Given this list of marker genes ACOT9, TICAM1, CHST2, BHLHE22 (basic helix-loop-helix family member e22), TXNL1, DUSP4, N4BP1, BMAL2, LINC03025, TXLNB, FBRS, CSF2RA, TAGLN2, CLN5, GRAMD1A, IRF7, AMPD3, PPFIBP2, CPA3, SMOX, INHBA, CLDND1, ARF3, GRAMD1C, MTFP1, TARS1, SPHK1, YIPF6, CARD16, TNIP3, SLC44A1, DCUN1D3 (defective in cullin neddylation 1 domain containing 3), MAD2L2 (NCBI Gene Id 10459), EAF1, TMEFF1, OSM, TGFA, ARFRP1, LMNB1, SPRED2, CSF2RB, HCK, MCM5, GCH1, GPR84, ITCH, RGS1, TNFRSF9, TPD52, MIR3945HG, PDGFRL, PLAUR, TRIP10, CLEC4D, CHMP5, F3, ELL2, BMP1, PSME1 (NCBI Gene Id 5720), MELTF, MFSD14B, PSMA1, NDEL1, GK3, RNF19B, ZNRF2, C3, CXCL8, MRPL14, PPP1R16B, CYTIP, PSTPIP2, EZH2, PLEKHM3, CYP27B1 (cytochrome P450 family 27 subfamily B member 1), AK4, CFLAR, LRRC32, ISG20, SMURF2, CLIC4 (chloride intracellular channel 4), ETHE1, TRAF1, ENSG00000284634, CLEC4A, ACSL5, LINC02912, FUT4, CD58 (NCBI Gene Id 965), ADA (adenosine deaminase), DCUN1D1, ARL8B, PIK3AP1, CMTM6, LAP3, PNRC1, PSMA2, IFITM3, NSRP1, P4HA1, RFFL, LINC00467, WBP4, DUSP5, HEXIM1, LYRM1, EYA3, TANK, POP4, CGAS (cyclic GMP-AMP synthase), IRF2, CARD19, JAG1, IRAK2, RAPGEF2, CASP1, SLC39A8, AKR1B1, DIXDC1, DESI1, CD44, SLAMF7 (SLAM family member 7), FMNL3, IL7, ERO1A, LRP8, PLPP1, IKBKE, SERPINE1 (serpin family E member 1), ADGRE1, RANBP9, SP4, CLEC4E, RAP1B, CSNK2A1, SERPINA1, SLAMF1, WTAP, BATF, ADM, PSME2, NDE1, APOO, RAD23A, ETV3, BID, PSMD14, EGLN3, NFKBIA, BBIP1, INO80C, MYO1G, ATP6V1H, DRAM1, DNAJC18, MKLN1, SLC25A25, TSPAN3, ACLY, ACOX3, SEMA4D, NABP1, NFKB1, CFB, MAP3K13, BTG1, RAB30, IFIH1, UGP2, GP1BA, CSRNP1, ACSL1, SNX10, SLC20A1, AHR (aryl hydrocarbon receptor), ADAM32, PHF11, PLGRKT, NMT1, CDS2, GABRB2, LYRM4, ALOX15B, ZIC2, LONRF1, UBE2Z, BCL3, MMP7, PTPN12, TNFAIP8, LINC00165, WWC2, G0S2, SOCS2, VRK2, CALM1, PSMA3, IFRD1, BTG3 (BTG anti-proliferation factor 3), here is a description of the gene set: Human Gene Set: GSE9960_HEALTHY_VS_GRAM_NEG_SEPSIS_PBMC_DN Genes down-regulated in peripheral blood monocytes (PMBC): healthy versus Gram negative sepsis. To identify signature genes that help distinguish (1) sepsis from non-infectious causes of systemic inflammatory response syndrome, (2) between Gram-positive and Gram-negative sepsis. from publication Payen D, Lukaszewicz AC (PMID 19535937) species: Homo sapiens